The following is a description of a gene set: studied in species Mus musculus Mouse Gene Set: MIR_1898 Genes predicted to be targets of miRBase v22 microRNA mmu_miR_1898 in miRDB v6.0 with MirTarget v4 prediction scores > 80 (high confidence targets). from publication Chen Y, Wang X (PMID 31504780), and this is the list of marker genes: Extl1 (NCBI Gene Id 56219), C9orf72, Slit2, Ehd1, Enc1, Sox21, Pitpnm3, Plk2, Kdm5a, Sgtb, Mbip, Fbxo30, Klhl13, Selenot, Porcn, Lce1i, Tub, Kif21a, Tnrc6b, Timp3, Sptssa, Cdk12, Fam199x, Sertad1 (SERTA domain containing 1), Mxd1, Baz1a, Dusp7, Ska3, Sgsm1, Pla2r1, Spock1, Dock8, Hivep1, Macir, Arpc1a, Lingo2, Ankrd28, Rbms3, Ctnnbip1, Septin10, Dbnl, Tmem170, 1810055G02Rik, Mkrn3, Spon2, Soat1, Eef1a1, Tcaf3, Col11a1, Gpr3, Tppp